The following is a description of a gene set: Mouse Gene Set: GOCC_BOUNDING_MEMBRANE_OF_ORGANELLE species: Mus musculus The lipid bilayer that forms the outer-most layer of an organelle., and this is the list of marker genes: Dab2, Ffar4, Tmem63b, Rap1gap, Creb3l2, Slc46a2, Mxra8, Tmem150b, Uba1, Irgm2, Ust, Vamp1, Bri3bp, Anxa6, Tap1, Stx5a, Ap1m2, Rab2b, Vps37a, Rsad2, Tmem108, Mfn1, Chst5, Sar1b (secretion associated Ras related GTPase 1B), Rab5c, Acap2, Rps29, Tlr8, Pi4ka, Vps35, Acrbp, Pde2a, Gnb1, Asph, Slc26a11, Gpr151, Atp11b, Bax, Hs3st5, St3gal2, Abcd3, Pgap6, Atp8b3, Dhcr7, Mcoln2, Gbp2, Cd300lg, Mgat1, Arl13a, Dlg1, Mbtps2, Galnt6 (polypeptide N-acetylgalactosaminyltransferase 6), Pdcd6, Rab31, Slc9a6, Cplx3, Ap5m1, Mmp14, St3gal6, B3galnt2, Tmem163, Marchf9, Rab33b, Scamp1, Itpr1, Arf6, Nat8f4 (NCBI Gene Id 75541), Zfyve16, St8sia6, Kif16b, Spag9, P2rx4, Kir3dl2, Tomm22, Mpeg1, Flot2, Atp13a5, Tfeb, Gfap, Mymk, Coasy, Tmed1, Fut10, Rhbdd2, Ppp1r15a, Gripap1, H2-DMa, Steap3, Cog8, Stxbp5, Fktn, Slc12a9, Gbp3, Snx5, Inpp4a, Camk2g, St8sia3, B3gnt2, Cyb561a3, Slc35f1 (solute carrier family 35, member F1), Ifitm7, Tmem87b, Camk2d, Oca2, Armcx6, Nlrp3 (NLR family, pyrin domain containing 3), Sec61a1, Tmem79, Slc25a46, Sec63, Atp13a2, Vps13a, Mmd2, Akap5, Robo1, Lamp1, Syt6, Cltb, Aph1a, Atp2c1, Yipf2, Stx8, Stam2, Tpst1, Atp6v1e1, Syt7, Ostm1, Pex2, Tmem150c, Gimap5, Nsg2, Acsl4, Ext1, Mgst1, Mios, Ifitm1, Zdhhc1, Mgat4b, Numb, Thbd, Chst8, Slc46a1, Rab11fip2, Kash5, Rock1, Gk, Golga2, Syne4, Ugt2b5, Rab10, Zfyve27, Trappc3, Zfyve9, Tmem175, Ugt2b1, St6galnac5, Chst1, Rapgef1, Phf24, Gcnt7, Qtrt2, Capn10, Stk26, Cltc, Depdc5, Slc7a14, Pkd2l1, Armc1, Blzf1, Ston1, B3gnt7, Syn3, Slc9a7, Pla1a, Oprk1, Gnpat, Nsg1, Grk2, Plaat3, Pam, Snx17, Hadhb, Slc36a1, Fam20c, Arl6, Ndst1, Abca12, Gorasp2, Ap1s2, Tmem130, Mvb12b, Spring1, Tpcn2, Abca7, Tomm70a, Cys1, Faah, Unc13c, Sidt2, Mpp4, Zdhhc2, B3gnt5, Mtx2, Chmp1a, Trappc4, Chmp2b, Maneal, Lyset, Hgsnat, Efcab7, Cfap65, Mctp1, Snapin, Spred2, Snf8, Snap91, Sec24b, Tlcd3b, Ebag9, Ret, Far1, Copg2, Slc5a7, Gosr2, Actr3, Plpp3, H2-K1, Ehd3, Atp6v1c2, Slc44a2, Tmem167, Rnf125, Synpr, Arfgef2, Ghrhr, Panx2, H2-Q1, Cog1, Pla2g2a, Ccdc136 (coiled-coil domain containing 136), Klhl41, H2-DMb1, Calm3, Clba1, Abcd2, Rab39, Galnt7, Slc35b4, Bcl2a1d, Wscd1, Fam210b, Septin8, Lrrc8e, Bbs7, Tmem106b, Slc9a4, Ocrl, Tmem138, Tecpr1 (tectonin beta-propeller repeat containing 1), Bad, Entpd4b, Glipr2, Agtr1a, Copg1, Atp6v0a4, Pex1, Trf (NCBI Gene Id 22041), Sypl2, Slc35a1, Armcx3, Srebf2, Arl8b, Txndc15, Vac14, Tlr7, Micall1 (NCBI Gene Id 27595), Nipsnap2, Man2a1, Rnft1, Gbp4, Atp6v1h, Kcnh1, Syt13, Gk2, Sytl4, Slc10a4, Fzd7, Large1, Scara5, Marchf2, Atg12, Hmgcr, Gbp2b, Spart, Chmp3, Fut9, Ticam2, Cd46, Tnks2, Lman1, Mvb12a, Sppl3, Vps11, Slc15a3, Vps45, Slc9c1, Snx27, Chp1, Rab3c, Mcoln3, Amn, Fndc3a, Stxbp2, Mosmo, Cnga2, Rac1, Neu3 (neuraminidase 3), Sorl1, Stard3, Rp9, Fam170b, Kics2, Abca2, Rab29, Emp2, Dtx3l, Ephb1, Golga4, BC004004, Rnf121 (NCBI Gene Id 75212), Smim26, H2-D1, Prkd1, Anxa1, Azin2, Usp30 (NCBI Gene Id 52294), Gga3, Mtor, Inpp5b, Myo7a, Dio3, Csf3r (colony stimulating factor 3 receptor), Fam20b, Rab14, St3gal5, Gp2, Smpd4, Slc27a2, Rabepk, Il17rd, Nucb2, Thsd1, Plekhm2, Ext2, Mmgt1, Atp6v1b1, Rragb, Tab2, Diaph3 (diaphanous related formin 3), Xylt2, Misfa, Marchf4, Bcap31, Synj2bp, Syne1, Doc2a, Epha8, Slc17a6, Cln8, Nat8f1, Zdhhc12, Pgap2, Tsc2, Glg1, Syt8, Slc7a5, B3gnt9, Mgat4a, Slc37a3, Rptor, Kif1b, Syndig1, Scara3, Rap2a, Atp2b1, Snn, Mcoln1, Cdip1, Tomm20l, Gpam, Zp3r, Cstad, Mfsd1, Dram2 (NCBI Gene Id 99690), Tmem109, Nprl2, Sln, Rragd, Kmo, Pex10, Atg16l1, Hpse, Nprl3, Borcs5, St8sia2, Mcl1, Jph2, Fkbp1a, Ap5s1 (NCBI Gene Id 99307), Pex6, Galnt17, A4gnt, Lrrk2, Alg5, Cav3, Slc8a3, Nipal1, Golga5, Itm2b (NCBI Gene Id 214227), Tex264, Gosr1, Ptprn, St6gal1, Laptm4b, Aifm1, Armh3, Cd63, Sec24c, Abhd17a, Ece2, Serinc3, Tmem59l, Slc25a17, Phaf1, B3gat1, Xylt1 (NCBI Gene Id 233781), Dll3, Wasf1 (NCBI Gene Id 83767), Hip1, Creb3l1, Prmt1, Gper1, Clcn5, Traf3ip3, Mrln, Strit1, Dop1a, Slc36a2, Gcnt3, Cdc42, Art1, Zdhhc15, Cd24a, Vmp1, Abca6, Igf2r, Maco1, Ryr1, Slc6a9, Tspear, Miga1, Exoc3, Atg9b, Gpi1, Gpnmb, Dhrs4, Fundc2b, Ndrg1, Rab1a, Scamp2, Slc3a1, Slc44a1, B4galnt1, Vopp1, Dnajc13, Mrc1, Creb3l4, Arf1, Slc6a7, Cyp2e1, Zdhhc13, Rab4b, B3gnt4, Clcn6, Ppt1, Gnpnat1, Slc17a7, Bcl2l10, Tmco1, Tpcn1, Scgn, Lman2, Tyr, Gnptab, Hyal5, Tomm7, Bsg, Akap6, Wdr44, Rdh11, Ldlr, Bri3, Serac1, Arfgef3, Ryr2, Tm9sf1, Dnajc5, Rab35, Gabarapl1, Ptgs2, Tcirg1, Rho, Mr1, Arf4, Smpd3, Msto1, Tfe3, Grina, Atp6v1g2, Mtch2, Snx18, Nrgn (neurogranin), Atg14, Ldlrad4, Prrt1, Pex13 (NCBI Gene Id 72129), Tmed3, Uvrag, Sypl1, Dele1, Tom1l1, Epn2, Bak1, Mkln1, Dmxl2, Stx7, Pcsk4, Rab3a, Bet1 (Bet1 golgi vesicular membrane trafficking protein), Gal3st1, Gcnt4, Cav2, Cop1, Syne2, B3galt1, Kif5b, Sec61b, Hyal2, Qsox2, Atp11c, St8sia1, Slc15a4, Bet1l, Galnt11, Atp10b, Asap1, Ankfy1, Mgat2, Gdap1, Ticam1, Hpd, Sstr3, Ap1g1, Mgarp, Zdhhc9, Nucb1, Sh3gl3, Znrf2, Eva1a, Snx2, Gnai3, Clec4e, Tnfrsf1a, Borcs6, Gabarapl2, Ugt2b38, Tsg101, Ccdc47, Psen1, Syngr3, Tomm5, H2-Q2, Mctp2, Slc27a1, Chmp7, Acsl6, Myo18a, Cemip, Zdhhc8, Gja1, Atp6v0b, Slc35b1, Apc, Sarm1, Bnip3, Kptn, Chst12, Stmp1, Dennd5a, Scyl2, Pde6b, Rab4a, Itpr2, Apoo, Snx21, Vps36, Gad1, Pikfyve, Th, Slc46a3, Rab34, St6galnac6, Rab15, Rps26 (NCBI Gene Id 27370), Aph1b, Dagla, B2m, Fzd5, Vdac3, Cln3, St8sia5 (ST8 alpha-N-acetyl-neuraminide alpha-2,8-sialyltransferase 5), Vapa, Bnip1, Copz2, Ric1, Dmbt1 (NCBI Gene Id 270001), Nat8f2 (N-acetyltransferase 8 (GCN5-related) family member 2), Plekhb1, Adam10, Rab8a, Abcc8, Tomm6, Tmem74, Itpr3, Agpat4, B3galt2, Dbnl, Vamp3, Pex3, Gria1, Commd1, Clstn3, Kir3dl1, Rab26, Ergic2, Mitd1 (NCBI Gene Id 69028), Cnp, Traf3, Rubcnl, Yipf6, Acap1, Scyl1, Lin7c (lin-7 homolog C, crumbs cell polarity complex component, NCBI Gene Id 99335), Chst7, Clint1, Lrpprc, Ubap1l, Ndfip1, H2-Q7, Ap2b1, Slc18a1, Rab2a, Anxa2, Bnip3l-ps, Cptp, Vma21, Cpt1a (carnitine palmitoyltransferase 1a, liver), Car4, Man1a2, Foxo3, Sec23a (SEC23 homolog A, COPII coat complex component), Pde6h, Tlr4, Nutf2-ps1, Syn1, Rab12, Mmd, Scg3, Eno1b, Pkdrej, Tex101 (testis expressed gene 101), Galnt10, Kdelr2, Shank3, H2-M10.6, Ssr4, Myo19, Aldob, Srl, Tm9sf2, Snx14 (sorting nexin 14, NCBI Gene Id 244962), Rap2c, Ica1 (NCBI Gene Id 15893), Exd2, Mief1, Spata18, Golph3, Grm6, Cd164, Bcl2l1, Arfgef1, Ift46, Gucy2d, Rab20, Mapkap1, Gnrh1, Eea1, Nras, Mppe1, Ap1s1, Snx4, Dhrs7c, Erc1, Galnt14, Abcd1 (ATP-binding cassette, sub-family D member 1), Prom1, Golga3, Ap1s3, Arc, Bok, Snx6, Gga1, Agps, H2-Aa, Hid1, Slc11a1, Rab23, Clmn, Rab5a, Slc26a7, Slc26a9, Tmem87a, Lin7b, Scnn1a, Cfp, Zpbp (zona pellucida binding protein), H2-M2, Septin2, Cd274, Pi4k2b, Stoml1, Osbp, Atp6v1d, Cherp, Ap2m1, Kdelr3 (KDEL (Lys-Asp-Glu-Leu) endoplasmic reticulum protein retention receptor 3), Myoc, Arfgap3, Snx12, Hs3st3a1, Faim2, Hk2, H2-Q10, Aspscr1, Pln, Arl3, Tbc1d5, Slc30a5, Mtarc2, Snx7, Mief2, Sntb2, Vps37b (NCBI Gene Id 69474), Fgd2, Ntrk1, Chmp6 (charged multivesicular body protein 6), Tnks, Grb14, Uevld, Samm50, Evc, Slc6a2, Sh3gl1, Dmd, Rab21, Gpr88, Washc1, Shh, Pgap4, Ehd1, Gria2 (NCBI Gene Id 14800), Atp6ap2, Dhh, Sec24a, Slc35c2, Sptbn2, Lamp3, Ptges2, Selp, Appl1, Jsrp1, Pld3, Lamtor1, Cux1, Zdhhc18, Fnip2, Tafa4, Ube2d3, Adcy8, Vdac2, Hps6, Oprd1, H2-Q6, Kif13a, Dse, Lysmd3, Anxa5, Moxd1, Shc1, Appl2, Or51e2, Ttc8, Pgam5, Tlr13, Ltc4s, Vamp4, Vps39, H2-DMb2 (histocompatibility 2, class II, locus Mb2), Slc30a1, Cbfa2t3, Dram1, Pkmyt1, Trip11, Sycn, Sybu, Cylc1, Spata31, Sgms2, Atp6v1g1, Sgta, Ncstn, Hyal3, Myo1b, Gga2, Paqr3, Rilp, Stk25, Rab3b, Abhd6, Cnga4, Wdr24, Cnga1, Bcl2a1a, Rnf152, Tapbpl (TAP binding protein-like), Tlr2, Syt12 (synaptotagmin XII), Ift88, Vamp2, Washc4, Mbtps1, Arg1, Plod2, Gpr157, Arfgap1 (NCBI Gene Id 98853), Cox14, Cdhr1, Syp, Minar2, Sacm1l, Tmc8, Cadps, Cyb5b, Has2, Mon2, Atp2c2, Abcb9, Cideb, Mchr1, Stx6, H2-Ab1, Arcn1, Rhot2, Tmem231, Chmp4c, Tbc1d20, Trpm7, Mtcl2, Scamp5, Cybrd1, Unc13a, Mreg, Sort1, Irgm1, Tepsin, H2-Eb2, Rpl27, Pxylp1, Calcoco2, Pdlim4, Atp9a, Mal2, Nav3, Zdhhc4, Rab9, Tmem95, Ceacam1, Tspo2, Znrf1 (zinc and ring finger 1), Baiap3, Galnt16, Ergic1, Wfs1, Snx16, Ubb, Glmp, Dhcr24, Pla2g4a, Lrba, Lpcat1, Lman1l, Wscd2, Drd5, Itm2c, Trappc3l, Wdr59, Slc35b3, Tm6sf1, Mitf, Slc66a1, Pfpl, Spaar, Scyl3, Zdhhc20, Stx12, Slc17a5, Yipf1, Reep5, Dipk2a, Steap2 (six transmembrane epithelial antigen of prostate 2), Cln5, Scap, Borcs8, Mgat5, Prkci, Washc2, Litafd, Slc29a3, Hax1, Srprb, Gcnt1, H2-Oa, Far2, Slc35d2, Golt1a (golgi transport 1A), Abcb1b, Trdn (triadin), Mfsd12, Tmed2, Muc20, Acbd5, Spire1, Pigr, Syne3, Slc2a6, Fndc5, Rxylt1, Rab7b, Bid, B3gnt3, Sox10 (NCBI Gene Id 20665), Atp6v0e2, Tmem199, Sri, Chst14, Pip4p1, Atp7a, Mphosph9, Atp6v0c, Grin1, Tmem97, Bloc1s2, Dao, Vps13b, Zmpste24, Vti1a, Hsp90ab1, Fcgrt, Mgst3, Ptprs, Emc6, Surf4, Plekhm1, Prkn, Pde6a, Glipr1l1 (GLI pathogenesis-related 1 like 1), Prkce, Spaca1, Seh1l, Myo5b, Rab5b, Galnt12 (polypeptide N-acetylgalactosaminyltransferase 12), Vps18, Pgap3, Cog6, Piezo1, Shank2, Wdr81, Rnf185, Cd1d2, Mfng, Rhou, Vps13c, Zdhhc21 (zinc finger, DHHC domain containing 21), Chst11, Rab27a, Tmem63a, Rph3a, Sparc, Rraga, Ier3ip1, Moxd2, Bin1, Wasl, Marchf1, Slc18b1, B4galt4 (NCBI Gene Id 66823), Tmf1, Armcx2, Ncf4, Rab13, Mpv17l, Slc50a1, Chpt1, Atp2a2 (ATPase, Ca++ transporting, cardiac muscle, slow twitch 2), Golga7, Zfyve1, Atp6v0d2, Wls, Snx20 (NCBI Gene Id 71607), Litaf, Sigmar1, Smcp, Qpctl, Atp8a1, Rcc2, Ntrk3, Syt11, Phtf1, Itprip, Cat, Drd1, Chst3, Ptrh2, Cubn, Dlg2, Mlxip, Slc36a4, Sec23b, Clip3, Ndst4, Lamtor3, Golim4, Cuzd1, Tm4sf5, Chmp4b, Ehd2, Casq1, Dnajc11, Slc22a2, Sun2, Adcy3, Sppl2b, Chst4, Rab8b, Slc35g2, Tmbim1, Ap3b2, St8sia4, Rab27b (RAB27B, member RAS oncogene family), Lamtor4, Tlr3, Slc18a3, Asah2, Clvs1, Vat1, Vdac1, Mfsd8, Bace2, Tmem17, Necap2, Svip, Tmem167b, Tmed10 (transmembrane p24 trafficking protein 10), Abhd17c, Fundc2, Sec16a, Stam, Srebf1, Tmed9, Ndst3, Rab36, Stard3nl, Elapor1, Ufl1, Ston2, Gbgt1, Lman2l, Hps4, Gpr108, Trim14, Cd68, Vps25, Slc32a1, Lfng (LFNG O-fucosylpeptide 3-beta-N-acetylglucosaminyltransferase), Nme3, Nat8b-ps, Ccz1, Atg9a, Prnp, H2-M10.1 (histocompatibility 2, M region locus 10.1), Atg4b, Actn1, Cav1, Miga2, Rfng, Nat8f5, B4gat1, Arl13b, Cog5 (component of oligomeric golgi complex 5), Golga7b, Pi4k2a, Steap4, Lmbrd1, Tvp23a, Syt1, Gcnt2, Notch1, Atf6, Clca1, Marchf8, Snx3, Tspo, Llgl1, Szt2, Mical1 (NCBI Gene Id 171580), Vps37d, Chmp1b2, Mymx, Pigbos1, Tlr6, Chst15, Vps53, Psen2, H2-T23, Tmem192, Sys1, Pde6g, Egfr, Slc30a2, Gabra2, Rab11fip1, Abcd4, Plod1, Asl, Tvp23b, Slc35c1, Gpr62, Drd2, Arhgap26, Acer3 (NCBI Gene Id 71401), Iqce, Bloc1s1, Slc39a4, Wdr91, Manea, Syngr2, Fcmr, Spaca3, Cnih1, Pex5, Tm6sf2, Galnt13, Vta1, Slc38a7, Rab32, Gaa, Entrep1, Slc16a13, Slc4a8, Srpra, Slc22a3, Mmgt2, Ap3d1, Akap1, Slc35b2, Slc11a2, Rab22a, Npc1, Gabarap, Atraid, Tprg1l, Snx10, Necap1 (NCBI Gene Id 67602), Gpr61, Abcb11, Mul1, Spata19, Rab38, Nbr1, Snx25, Rap2b, Rab11fip4, Tmem132a, Rab6b, Pmepa1, Pnpla8 (NCBI Gene Id 67452), Entpd4, Acacb, Syt10, Tomm20, Steap1, Slc30a4, Cpe, Deptor, Pjvk, Abcb4, Rhot1, H2-M10.4, Atp6v1c1, Bbs5, Map6, St6galnac4, Ccdc115, Gpr89, Dnm1l, Chmp2a, Slc31a2, Pld1, Bbs2 (Bardet-Biedl syndrome 2), Phb2 (NCBI Gene Id 12034), Pex11b, Man1a, Decr2, Huwe1, Trabd (NCBI Gene Id 67976), Slc38a9, Gpsm1 (G-protein signalling modulator 1 (AGS3-like, C. elegans)), Abcc5, Rtn1, Slc31a1, Man2a2, Rnf167, Clstn1, Dgki, Slc25a47, Rab11fip3, Rep15, Rnf24, Ace3, Sec23ip, Stk24, Ap3b1, Marchf5, Pla2g4e (phospholipase A2, group IVE), Parm1, Rnd2, Plekhb2, Vps16, Vps37c, Snx13, Pnliprp2, Abcb6, Nkg7, Nat8f6, Ppp2r2b, Wdfy3, S2bpcox16, Maob, Gcc1, Sv2b, Snap29, Sec16b, Bcl2a1b, Ppp1cc, Snx8, Vps28, Tmem184a, Rhov, Sar1a, Rragc, Gba2, Slc18a2, Rnasek, Tom1, Pex26, Gbp5, H2-M11, Aifm2, Acsl5, Syt5, Prom2, Sting1, Suco, Ulk1, Laptm4a, Acbd3, Rtn4ip1, Atl1, Sphk1, H2-M10.2, Slc36a3, Sec61g, Hsd17b6, Clta, Plekhf2, Usp32, Ifitm2, Becn1, Slc1a1, Ftcd, Vps33a, Rab6a, Bcl2a1c, Bcl2, Pex16 (peroxisomal biogenesis factor 16), Chst2, Camk2b, Snx1, Ncdn, Rnd3, Atp8a2, Scfd1, Tigar, Rhob, Galnt15, Rnf13, Phb1, Entpd6, Rmc1, Slc39a14, Osbpl11, Fnip1, Gpr37l1, Qsox1, Tsc1, Anxa4, Slc30a10, H2-M5, Dmtn, Slc6a4, Spaca6, Eqtn, Nos1ap, B3gnt6, Ryr3, Armc12, Slc9a9, Mlst8, Tpst2, Smo, Rph3al, Tmem38a, Rps28, Izumo3, Ubxn6, Lpin1 (NCBI Gene Id 50494), Pkd2 (NCBI Gene Id 77380), Gnptg, Grin2b, Mfn2, Synrg, Syngr4, Tmem9, Cog7, St6galnac2, Adam8, Fkbp1b, Sec24d, Rps6kb1, Gpr155, Plce1 (phospholipase C, epsilon 1), Bnip3l, Pex19, Zdhhc14, Srgn, Has3, Rictor, Pcsk5, Slc17a8, Copa, Stx1a, B3gat3 (NCBI Gene Id 72727), Evc2, Cc2d1a, Pycard, Atp6v0d1, Rras2, Amph, Rgp1, Tex261, Pi4kb, Hk1, Jmy (junction-mediating and regulatory protein), Sec31b, Rer1, Sytl2, Bbs9, Acsl1, Gpr137c, Sphk2, Itfg2, Scamp4, Rufy1, Acp2, Svop, Eps15, Sv2c (synaptic vesicle glycoprotein 2c), Mgat5b, Arl6ip1, B3galnt1, Vps4b, Nme1, Fis1, Tmem190, Tfrc, Usp8 (ubiquitin specific peptidase 8), Pex11a, Prrg4, Atp2a1, Bbs4, Slc9a8, Mtfr1l, Tmem35a, Ass1, Mff, Mtx3, Atp8b5 (ATPase, class I, type 8B, member 5), Rffl, Rab7, Abcc4, Rb1cc1, Rmdn3, Tyrp1, Gba1, Agtrap, Neu1, Aqp4, Nat8, Abcg4, M6pr (mannose-6-phosphate receptor, cation dependent), Mtx1, Vps29, Rab43, Rasgrp1, Gpr161, Nlrx1, Paqr4, Tmem9b, Jph1 (junctophilin 1), Ap4b1, Trim23, Rab11a, Ehd4, Lamp5, Coro7, Slc10a7, Lamtor2, Arhgap21, Gimap1, Mal, Cc2d1b (NCBI Gene Id 319965), Tasl, Sgms1, Tomm40l, Letmd1, H2-T22, Clcn3, Trpm2, Cyb561, Rab11fip5, Slc15a2, Osbpl6, Syt3, Kxd1, Slc35a4, Gpr143, Atp13a3, Creb3, Slc9a3, Flcn, Slc45a2, Gad2, Trim37, B3galt5, Emd, Sema4c, Ndst2, Sfxn2, Cask, Aftph, Hspa8, Spaca4, Pex12, Arfip1, Rheb, Rnf183, Washc5, Lpcat2, Tmem59 (transmembrane protein 59), Moap1, Ctsd, Cd1d1, Fut11, Pip4p2, Casd1, Arfgap2, Hras, Slc30a8, Galnt4, Nutf2, Gpr137b, Epm2a, Zdhhc19, Htr4, Slc35a3, Armcx1, Napepld, Tmem165, Slc2a1, Grn, Qtrt1, Hs2st1, Slc17a9, Syt9, Enthd1, H2-T3, Aqp2, Slc49a4, Clcn4, Dtnbp1, Cnr1, Uso1, Zdhhc22, Samd8, Pja2, Mtmr4, Prcd, Phlpp2, Igtp, Acer2, Copb1, Mavs, Nos1, Syn2, Otof, Dcst2, H2-Eb1, Pml, Pmel, Gfy, D130043K22Rik, Man1c1, Plpp2 (phospholipid phosphatase 2), Atad1, Trappc2b, Whamm, Chrna7, Atf2, AU040320, Plec, Ubc, Sesn2, Spns2, Tas2r108, Gucy2e, Hs3st2, A4galt, Chmp1b, Zc3h12a (NCBI Gene Id 230738), Anp32e, Calm1, Mtarc1, Slc3a2, Kif1a, Mtmr2 (NCBI Gene Id 77116), Yif1b, Gask1b, Meak7, Tmem30a, Hrc, Sppl2c, Epn3, Dmpk, Tbc1d7 (NCBI Gene Id 67046), Galntl5, Pla2g4b, Spns1, Tmem225, Fbxl4, Bcl2l2, Dop1b, Sppl2a, Ap2s1, Inpp5e, Zg16, Stx17, Aqp1, Sun1, Rpn2, Klc2, Copb2, Pomgnt1, Galnt18, Pdcd10, Arpc2, Large2, Zfyve28, Treml4, Stx18, Mall, Sorcs2, Map1lc3a (microtubule-associated protein 1 light chain 3 alpha), Vps41, Scarb2, Slc22a17, Slc9b2, Nmnat2, Hs3st6, Mtch1, Rom1, Ptprn2, Ntrk2, Sec22b, Vps33b, Cog2, Atp6v1g3, Zdhhc17, Lin7a, Prrt2, Tmem135, Ap2a1, Vti1b, Epha4 (Eph receptor A4), Rhbdf1, Atp6ap1, Opa1, Acsl3, Serpina5, Arl1, Ykt6, Hace1, Pld6, Osbpl9, Zdhhc23, Fkrp, Rassf9, Nelfb (NCBI Gene Id 99058), Ergic3, Atxn3, Slc6a17, Hgs, Tekt3, Lrrc8a, H2-Ea, Reep6, Pxmp4, Atm, Clcn7 (NCBI Gene Id 28069), Anxa8, Tmem50b, Ifitm3, Ihh, B4galnt2, Clvs2, Washc3, Lztr1, Ift27, Atp6v1b2, Pip5k1c, Tmbim4, B3galt4, Rtn2, Doc2b, H2-Ob, Arl8a, Stim1, Tmem45b, B3gat2, Galnt5, Hhat, Tspan1, Cisd2, Abhd17b, Arhgap1, Ubiad1, Pkd1l1, Vps26a (NCBI Gene Id 30930), Retsat, Abhd2, Gbf1, Stx16, Clstn2, Furin, Rab9b, Bbs1, Slc22a21, Cftr, St6galnac3, Umod, Pcsk7, Pitpnb, Tafazzin, Gpr137, Vps4a, Map4k2, Erbb2, Fundc1, Sh3gl2, Rab11b, Leprot, Hs3st3b1, Chst9, Slc35a5, Pgrmc1, Mospd1, Pacsin2, Sec61a2, Slc48a1, Cpt1b, Lmtk3, Cyb5r3, Arhgap32, Lamtor5, Stx3, Sbf2, Cope, Arhgap10, Nat8f3, Chmp5, Tmem53, Ctns (cystinosis, nephropathic), Pex11g, Pef1, St6galnac1, Dcst1, Snx30, Pebp1, Cd177, Copz1, Mapk8ip3, Itch, Tlr1, Atp13a4, Zdhhc3, Zdhhc7, Zdhhc11, Kcnq1, Acox1, Camk1g (calcium/calmodulin-dependent protein kinase I gamma), Canx, Pex5l (NCBI Gene Id 69422), Maoa, Syt2, Sv2a, Ap2a2, Gimap3, Dennd1a, Tspan15, Scamp3, Coro1a, Slc35f6, Ap1b1, Hip1r, Hepacam2, Gpr135, Calm2, Gopc (NCBI Gene Id 94221), Pptc7, Fig4, Neu4, Mt3, H2-M3, Dync1li1, Tmed5, Wipi1, Cmtm6, Pxmp2, Lamp2, Cbarp, Abca5, Coro1c, Praf2, Ttyh1, Rab18, Rtn3, Unc50, B3galt9, Slc39a13, Tlr9, Dnm2, Pecr, Abca3, Cspg5, Prph (peripherin), Cabp1, Sgip1, Slc35d3, Hvcn1, Golt1b, Atp6v0a1, Abcg1, Epn1, Klhl12, B3gnt8, Sec13, Mgat4d, Mgat4c, Kdelr1, Vps52, Map1lc3b, Psenen, Glce, 4930550C14Rik, Syt4, Rab17, Slc2a3 (NCBI Gene Id 57873), Snca, Tmem67, B3galt6, Tmem203, Marchf3, Atp6v1f, Scoc, Dcstamp, Eno1, Ubap1, Chst10, Pex14, Cog4, Bbip1, Rbsn, Atr (ataxia telangiectasia and Rad3 related), Ugt2b37, Anxa7, Aqp8, Znfx1, Laptm5, Btbd8, Atp6v0a2, Gpat2, Tomm34, Slc9a5, Mgat3, Slc25a4, Nat8f7, Unc13b, Anxa3, Cracr2a, Slc35a2, Ugcg, Fate1, Slc30a7, Naa60, Ap1g2, Tomm40, Plin3, Clec16a, Borcs7, Atp2a3, Syngr1, Dct, Mfge8 (NCBI Gene Id 17304), Slc30a3, Dbh, Acp3, Vamp8, Izumo1, Sec31a, Insr, Armc10, Pink1, Eef1ece2, Tapbp, Slc39a8, Sh3glb1, Yif1a, Ocln, Atp6v1a (ATPase, H+ transporting, lysosomal V1 subunit A), Cisd1, Ap1m1